The following is a description of a gene set: part of: SWI/SNF chromatin remodelers A non-canonical form of the BAF complex (ncBAF) was identified in mammalian cells by gradient sedimentation and by IP-mass spectrometry studies against SMARCA4 or BRD9. Unlike cBAF and pBAF, ncBAF does not contain SMARCE1 or SMARCB1, nor does it contain ARID1A/ARID1B, ARID2 or any BAF45/DPF family member; ncBAF is characterized by inclusion of complex-specific subunits BIRCA or BICRAL (also known as GLTSCR1 and GLTSCR1L, respectively) and BRD9. ncBAF localizes to CTCF binding sites and plays a role in prostate cancer, synovial sarcomas, some leukemias and and rhabdoid tumors. studied in species Homo sapiens Reactome Pathway: Formation of the non-canonical BAF (ncBAF) complex, and this is the list of marker genes: BCL7A, BRD9, SMARCA2, SMARCC2, ACTL6A, BICRAL, SMARCA4, SS18, BCL7B, BCL7C, SMARCC1, SMARCD2, ACTB, SS18L1, SMARCD3 (NCBI Gene Id 6604), SMARCD1, BICRA